The following is a description of a gene set: Human Gene Set: WP_ID_SIGNALING ID signaling studied in species Homo sapiens, and this is the list of marker genes: MYOD1, CDK2, PAX8, ID1, ID2, SREBF1, PAX2, ELK3, ELK1, CCNE1, ELK4, RBL2, ID3, RB1, RBL1, PAX5